Given this list of marker genes RIMS4, DAPL1, KMT2A, CHST9, FNDC9, HLA-DRA, CACNA2D1, UNC45B, DYNLT2, ITPR2, MKRN2, RSPH4A, CCL24, PYCARD, NKX2-1, TMEM121B, SPIN1, here is a description of the gene set: Genes up-regulated in small intestine upon loss of both APC and MBD2. from publication Phesse TJ, Parry L, Reed KR, Ewan KB, Dale TC, Sansom OJ, Clarke AR (PMID 18644872) We have previously shown that deficiency of the methyl binding domain protein Mbd2 dramatically reduces adenoma burden on an Apc(Min/+) background. To investigate the mechanism underlying this phenomenon, we have determined the effect of Mbd2 deficiency upon the phenotypes imposed by the conditional deletion of Apc in the small intestine. Microarray analysis demonstrated a partial suppression of the Wnt pathway in the absence of Mbd2. Mbd2 deficiency also influenced one immediate cellular consequence of Apc loss, with normalization of Paneth cell positioning. From a mechanistic perspective, we show that deficiency of Mbd2 elevates levels of the known Wnt target Lect2, and we confirm here that Mbd2 binds the Lect2 promoter in association with NuRD. Furthermore, we show that Lect2 is capable of functioning as a Wnt pathway repressor. These results therefore provide a mechanistic basis for the epigenetic control of adenoma formation mediated through Mbd2. studied in species Mus musculus Human Gene Set: PHESSE_TARGETS_OF_APC_AND_MBD2_UP